Given this list of marker genes SMYD5, PART1, SLC18A1, KANK3, PLXNA3, TANC2, MSH3, DKK4, RBMXL1, CYP11A1, GMPR, KANK2, FRYL (NCBI Gene Id 728298), MAGI1, POU6F2, IL16, STARD5, B4GALT6, P2RY10, SLC17A3, IFNW1, BRCA1, ZBTB22, TGFBR1, GNG4, NPFF, ATP4B, CCR3, SLC24A1, IL13RA1, NR2F1, NPAS2, CPEB3, HAAO, CAMK4, CMA1, CEACAM4, OPRL1, EN2, SGPL1, MLN, CBLN1, ZNF134, SCAMP1, PIAS2, CMKLR2, ZNF202, GABRB2, CDYL, DGCR5, TRIM24, CTRL, LMO1, WNT2B, SULT4A1, MON2, MT4, PTEN (phosphatase and tensin homolog), KRT2, HTR7, IPO9, KRT33A, MSL3, ELAVL2, GRIK5, BMP10, SLC13A2, EXOC4, ZNF500, RREB1, TSSK2, PAX7, EPHB2, FSHR, MYOZ3, MGA, ERC1, TBX5, RNF24, CD3E, FOSL1, SLC4A8, KRT34, S100A5, MAP2K7, CELA2B, EDIL3, MYL3, SLC15A1, RPS6KA5, COL19A1, SULT2B1, PHLDB1, HOXD4, JRK, TACC2, CD8A, SPA17, RFC5 (replication factor C subunit 5), MINDY2, PAXIP1, UBE4B, USP20, LRP6, ZNF710, NF1, HTR1E, ATP8A2, APOBEC1 (apolipoprotein B mRNA editing enzyme catalytic subunit 1), CNKSR1, PAX9, DRC3, BRD4, SRPK3, PVR, IL7, AQP7, ZNF266, HTR4, NRP2 (NCBI Gene Id 8828), ERCC4, ZNF33B, INSIG2, FOXD1, SCAPER, HTR1B, F2RL3, HCRTR2, CTSB, PAX6, CADM4, WBP4, MAP2, CXCL5, RUNX1, TRIO, ACO1, SLC2A1, TFDP2, TBC1D22A, ZNF133, ITGBL1, IL4 (interleukin 4), GNPAT, ASB4, SYNJ2, NEB, ACKR1 (atypical chemokine receptor 1 (Duffy blood group)), GJB5 (gap junction protein beta 5), SCN7A, CYP2D6, KNG1, PLEKHB1, FLT1, TBX19, AFF2, KRT86, HTR3A, COQ7, CNTN6, DEPDC5, BRD1, ATRX, ARL3, HNF1A, NXPE3, ZSCAN26, NTNG2, CYP2E1, MC5R, TNK1, ULK2, AMFR, COLQ, C1orf216, TNFRSF25, PPP1R3D, ZBTB14, LORICRIN, ABO, POU6F1, ATP8B1, ATF2, IVL, DNAJC16, OPLAH, NFAT5, CYP2C19, CPB2, PLPPR4, TMEM26, BCL2L11, SLC17A7, PARVB, DAPK2, PDE4A, EXTL3, NR0B2, ABCB10, GPR18, PDPN, MSX1, CHRNB4, ADAMTSL3, OSBP, F2RL1, IGF2, DPT, ABCB1, ADRA1A, UTRN, CALN1, PIK3C2A, ACACB, SERPINA4, MAGEA8 (NCBI Gene Id 4107), DTNA, NHEJ1, BTD, CPZ, POLR2K, FGF18, TBXT, ZNF132, PTPRB, PSG1, ELL2, ADAM20, CDC42BPA, ADCY3, PHF10, HOXC11, ITIH3, GTSE1, IFNA1, ZNF592, GRIP2, FXYD2, NTPCR, ATP2B2, NFX1, MYH2, SLC6A11, GPR171, CHST7, ATP6V1B1, MLLT10, UPK1A, CAMK2G, ZBTB40, FIG4, NR1I2, MDM2, RORB, SIX6 (NCBI Gene Id 4990), TIE1, LGI1, GABRA1, DMPK, SLC6A2, RYR3, ATXN3, PPP1R12B, MYO9B (NCBI Gene Id 4650), AKAP3, PPP1R1A, PRIM2, TAF12, GLE1, JADE3, OR2B6, COX6A2, USP46, TNIK, GPR15, ZNF200, PGM3, CXCR3, FNTB, SPRR2C, SLC33A1, CFH, POLR1HASP, STAC, POP4, NR2C1, ZNF157, AGPS, GPATCH8, PPP2R5B, PTPRS, LCOR, CACNB1, NR3C2, PSD, BCL2 (BCL2 apoptosis regulator), ARFGEF2, IFT27, JRKL, MC2R, LY9, KCNA5, ECE1, BNIP1, MAGEA9 (NCBI Gene Id 4108), LILRA4, ZP2, ITPKB, RUNX2, SFRP4, GPR19, POFUT2, FUT6, JAG1, CYP4F2, NRXN1, HIC2, RB1CC1, PSMF1, MFN1, POU3F4, CD6, SEZ6L, SGCD, MPZL1, VKORC1, CDH4, STK17A, HABP4, AMMECR1, SOCS6, RXRG, ESR1, MASP2, NCKIPSD, SLC30A3, CLOCK, FAS, AQP5, FRY, CEP162, FZD5, PRKCA, PDE4D, CBARP, ABCB9, GCA, CDC73, SLC16A5, SUPT3H (SPT3 homolog, SAGA and STAGA complex component), PPM1E, KRR1, FPR2, LILRA1, GRIK1, SMG1, SYT5, KLHL18, GHRHR, GCM1, HCRT, PRELID3A (NCBI Gene Id 10650), KLRC4, LTBP4, VPS35L, ATP6V0A2, ABCC8, SLC46A3, PCM1, PIGR (polymeric immunoglobulin receptor), ITIH4, NRTN, NOS2, IGKV7-3, ADCYAP1, TMEM11, SIM2, MYT1, NOTCH4, AOC4P, RAD51D, CCL16, IL11RA, RSC1A1, KAZN, INPP5E, TENM4, KIAA0586, COL8A1, IQCK, CLPX, LPGAT1, IL13, H3C6, LECT2, CRHR1, COLGALT2, SLC22A6, BARX2, DOCK1, PHOX2B, TTI1, PIK3CB, SLC4A3, PDE6A, HSD3B2, here is a description of the gene set: studied in species Homo sapiens Neighborhood of FOSL1 FOS-like antigen 1 in the MORF expression compendium Human Gene Set: MORF_FOSL1 Neighborhood of FOSL1